The following is a description of a gene set: Reactome Pathway: Transcriptional Regulation by MECP2 part of: Generic Transcription Pathway studied in species Homo sapiens MECP2 is an X chromosome gene whose loss-of-function mutations are an underlying cause of the majority of Rett syndrome cases. The MECP2 gene locus consists of four exons. Both exon 1 and exon 2 contain translation start sites. Alternative splicing of the second exon results in expression of two MECP2 transcript isoforms, MECP2_e1 (MECP2B or MECP2alpha) and MECP2_e2 (MECP2A or MECP2beta). The N-terminus of the MECP2_e1 isoform, in which exon 2 is spliced out, is encoded by exon 1. The N-terminus of the MECP2_e2 isoforms, which includes both exon 1 and exon 2, is encoded by exon 2, as the exon 2 translation start site is used. Exons 3 and 4 are present in both isoforms. The MECP2_e2 isoform was cloned first and is therefore more extensively studied. The MECP2_e1 isoform is more abundant in the brain. Mecp2 isoforms show different expression patterns during mouse brain development and in adult brain regions. While Rett syndrome mutations mainly occur in exons 3 and 4 of MECP2, thereby affecting both MECP2 isoforms, some mutations occur in exon 1, affecting MECP2_e1 only. No mutations have been described in exon 2. Knockout of Mecp2_e1 isoform in mice, through a naturally occurring Rett syndrome point mutation which affects the first translation codon of MECP2_e1, recapitulates Rett-like phenotype. Knockout of Mecp2_e2 isoform in mice does not result in impairment of neurologic functions. In Mecp2 null mice, transgenic expression of either Mecp2_e1 or Mecp2_e2 prevents development of Rett-like phenotype, with Mecp2_e1 rescuing more Rett-like symptoms than Mecp2_e2. This indicates that both splice variants can fulfill basic Mecp2 functions in the mouse brain. Changes in gene expression upon over-expression of either MECP2_e1 or MECP2_e2 imply overlapping as well as distinct target genes.<p>Methyl-CpG-binding protein 2 encoded by the MECP2 gene binds to methylated CpG sequences in the DNA. The binding is not generic, however, but is affected by the underlying DNA sequence. MECP2 binds to DNA containing 5 methylcytosine (5mC DNA), a DNA modification associated with transcriptional repression, both in the context of CpG islands and outside of CpG islands. In addition, MECP2 binds to DNA containing 5 hydroxymethylcytosine (5hmC DNA), a DNA modification associated with transcriptional activation. MECP2 binds to DNA as a monomer, occupying about 11 bp of the DNA. Binding of one MECP2 molecule facilitates binding of the second MECP2 molecule, and therefore clustering can occur at target sites. MECP2 binding to chromatin may be facilitated by nucleosome methylation.<p>MECP2 was initially proposed to act as a generic repressor of gene transcription. However, high throughput studies of MECP2-induced changes in gene expression in mouse hippocampus, and mouse and human cell lines indicate that more genes are up-regulated than down-regulated when MECP2 is overexpressed. At least for some genes directly upregulated by MECP2, it was shown that a complex of MECP2 and CREB1 was involved in transcriptional stimulation.<p>MECP2 expression is the highest in postmitotic neurons compared to other cell types, with MECP2 being almost as abundant as core histones. Phosphorylation of MECP2 in response to neuronal activity regulates binding of MECP2 to DNA, suggesting that MECP2 may remodel chromatin in a neuronal activity-dependent manner. The resulting changes in gene expression would then modulate synaptic plasticity and behavior. In human embryonic stem cell derived Rett syndrome neurons, loss of MECP2 is associated with a significant reduction in transcription of neuronally active genes, as well as the reduction in nascent protein synthesis. The reduction in nascent protein synthesis can at least in part be attributed to the decreased activity of the PI3K/AKT/mTOR signaling pathway. Neuronal morphology (reduced soma size) and the level of protein synthesis in Rett neurons can be ameliorated by treating the cells with growth factors which activate the PI3K/AKT/mTOR cascade or by inhibition of PTEN, the negative regulator of AKT activation. Mitochondrial gene expression is also downregulated in Rett neurons, which is associated with a reduced capacity of the mitochondrial electron transport chain. Treatment of Mecp2 null mice with IGF1 (insulin-like growth factor 1) reverses or ameliorates some Rett-like features such as locomotion, respiratory difficulties and irregular heart rate.<p>MECP2 regulates expression of a number of ligands and receptors involved in neuronal development and function. Ligands regulated by MECP2 include BDNF, CRH, SST (Somatostatin), and DLL1. MECP2 also regulates transcription of genes involved in the synthesis of the neurotransmitter GABA – GAD1 and GAD2. MECP2 may be involved in direct stimulation of transcription from the GLUD1 gene promoter, encoding mitochondrial glutamate dehydrogenase 1, which may be involved in the turnover of the neurotransmitter glutamate. Receptors regulated by MECP2 include glutamate receptor GRIA2, NMDA receptor subunits GRIN2A and GRIN2B, opioid receptors OPRK1 and OPRM1, GPRIN1, MET, NOTCH1. Channels/transporters regulated by MECP2 include TRPC3 and SLC2A3. MECP2 regulates transcription of FKBP5, involved in trafficking of glucocorticoid receptors. MECP2 is implicated in regulation of expression of SEMA3F (semaphorin 3F) in mouse olfactory neurons. In zebrafish, Mecp2 is implicated in sensory axon guidance by direct stimulation of transcription of Sema5b and Robo2. MECP2 may indirectly regulate signaling by neuronal receptor tyrosine kinases by regulating transcription of protein tyrosine phosphatases, PTPN1 and PTPN4.<p>MECP2 regulates transcription of several transcription factors involved in functioning of the nervous system, such as CREB1, MEF2C, RBFOX1 and PPARG.<p>MECP2 associates with transcription and chromatin remodeling factors, such as CREB1, the HDAC1/2-containing SIN3A co-repressor complex, and the NCoR/SMRT complex. There are contradictory reports on the interaction of MECP2 with the SWI/SNF chromatin-remodeling complex. Interaction of MECP2 with the DNA methyltransferase DNMT1 has been reported, with a concomitant increase in enzymatic activity of DNMT1.<p>In addition to DNA binding-dependent regulation of gene expression by MECP2, MECP2 may influence gene expression by interaction with components of the DROSHA microprocessor complex and the consequent change in the levels of mature microRNAs.<p>Increased MECP2 promoter methylation is observed in both male and female autism patients. Regulatory elements that undergo methylation are found in the promoter and the first intron of MECP2 and their methylation was shown to regulate Mecp2 expression in mice. Mouse Mecp2 promoter methylation was shown to be affected by stress.<p>The Rett-like phenotype of Mecp2 null mice is reversible, but appropriate levels of Mecp2 expression need to be achieved. When Mecp2 expression is restored in astrocytes of Mecp2 null mice, amelioration of Rett symptoms occurs, involving non-cell-autonomous positive effect on mutant neurons and increasing level of the excitatory glutamate transporter VGLUT1. Microglia derived from Mecp2 null mice releases higher than normal levels of glutamate, which has toxic effect on neurons. Increased glutamate secretion may be due to increased levels of glutaminase (Gls), involved in glutamate synthesis, and increased levels of connexin-32 (Gjb1), involved in glutamate release, in Mecp2 null microglia. Targeted deletion of Mecp2 from Sim1-expressing neurons of the mouse hypothalamus recapitulates some Rett syndrome-like features and highlights the role of Mecp2 in feeding behavior and response to stress.<p>Mecp2 overexpression, similar to MECP2 duplication syndrome, causes neurologic phenotype similar to Rett. The phenotype of the mouse model of the MECP2 duplication syndrome in adult mice is reversible when Mecp2 expression levels are corrected., and this is the list of marker genes: MIR137, SIN3A, HDAC2, CAMK2D, MOBP, PRKACA, CAMK2A, HDAC3, NCOR1, OPRM1, PTPN4 (protein tyrosine phosphatase non-receptor type 4), TNRC6C, CRH, HDAC1, BDNF, AGO4, NOTCH1, MECP2, GRIA2, SST, DGCR8, MEF2C, DLL1, FKBP5, AGO3, RBFOX1, GAD1, GRIN2A, HTT, MIR132, TBL1XR1, FOXG1, AGO1 (NCBI Gene Id 26523), LBR, SOX2, PPARG, GAD2, GRIN2B, TBL1X, TNRC6A, AURKB, CAMK4, OPRK1 (opioid receptor kappa 1), PTEN, GAMT, CAMK2G, CREB1, GPS2, TNRC6B, CALM1, HIPK2 (homeodomain interacting protein kinase 2), NCOR2, IRAK1, PVALB (parvalbumin), AGO2, SGK1, GPRIN1, TRPC3, MET, CAMK2B, MOV10, PTPN1, SLC2A3